The following is a description of a gene set: part of: Signaling by ERBB2 species: Homo sapiens Reactome Pathway: GRB7 events in ERBB2 signaling Heterodimers of ERBB2 and ERBB3 are able to bind GRB7 through phosphorylated tyrosine residues in the C-tail of ERBB3 (Y1199 and Y1262), but the exact downstream signaling of this complex has not been elucidated. GRB7 can recruit SHC1 to the active ERBB2 complex, and contributes to ERBB2 signaling-induced RAS activation, which promotes cellular proliferation, but the exact mechanism has not been elucidated. In addition, GRB7 can be phosphorylated by the integrin-activated PTK2 (FAK), leading to VAV2-dependent activation of RAC1 and promotion of cell migration. The exact mechanistic details of GRB7-induced RAC1 activation are not known., and this is the list of marker genes: NRG1, ERBB2, GRB7, ERBB3, NRG2